The following is a description of a gene set: Mouse Gene Set: GOBP_MITOTIC_CYTOKINESIS A cell cycle process that results in the division of the cytoplasm of a cell after mitosis, resulting in the separation of the original cell into two daughter cells. species: Mus musculus, and this is the list of marker genes: Ect2 (ect2 oncogene), Kif20a, Rab11a, Arf6, Myh14, Son, Poldip2, Klhdc8b, Vps4b, Cfl1, Apc, Rtkn, Ankrd53, Chmp2a, Chmp4c, Arf1, Rab35, Stambp, Unc119, Sptbn1, Snx9, Iqgap3, Exoc5, Myh10, Mitd1, Exoc8, Lzts2, Cul7, Nup62, Zfyve19, Cenpa, Stmn1, Rab11fip3, Daxx, Chmp3, Exoc3, Chmp1b, Incenp, Stx2 (NCBI Gene Id 269706), Exoc4, Zfyve26 (NCBI Gene Id 77517), Exoc7 (exocyst complex component 7), Rhob, Efhc1, Chmp4b, Arl3, Chmp1b2, Rhoc, Pdcd6ip, Racgap1, Exoc6b, Birc5, Map9, Plk1, Zfp365, Rock1, Ckap2, Jtb, Anln, Spast, Chmp2b, Cit, Iqgap1, Snx33, Chmp5, Rock2, Mtmr4, Exoc2, Kif4, Bbs4, Exoc6, Wnk1, Ank3, Spart, Cdca8, Kif20b, Cep55, Usp8, Kif23 (NCBI Gene Id 97568), Nusap1 (nucleolar and spindle associated protein 1), Snx18, Cntrob (centrobin, centrosomal BRCA2 interacting protein), Chmp6, Vps4a, Trim36, Septin7, Aurkb, Chmp7, Iqgap2, Ist1, Rhoa, Chmp1a, Exoc1